Given this list of marker genes NMRAL1, ASS1, here is a description of the gene set: Reactome Pathway: ASS1 variants cause citrullinemia Argininosuccinate synthase (ASS1) plays a critical role in the detoxification of ammonia, catalyzing the third step of the urea cycle, the ATP-dependent condensation of citrulline and aspartate to yield argininosuccinate. ASS1 is a cytosolic enzyme that is expressed at highest levels in hepatocytes, but is also expressed in the kidney at lower levels. <br>Mutations in ASS1 cause type 1 citrullinemia (OMIM 215700), an autosomal recessive inborn error of metabolism affecting ~ 1 in 250,000 live births. Like other urea cycle disorders (UCDs), citrullinemia is characterized by hyperammonemia. Enzyme deficiency is also associated with high plasma levels of citrulline, glutamine, and orotic acid, with low arginine. Severe cases of citrullinemia result in encephalopathy, characterized by lethargy, vomiting, seizures, coma and death. <br>Over 100 distinct disease-causing variants have been cataloged, including missense, nonsense, splice-site, deletions, and frameshift mutations. While some variants are identified in multiple cases, such as the most common allele G390R, others are private. Missense mutations typically disrupt enzyme folding or active‑site interactions (citrulline/aspartate binding), reducing catalytic activity.<br>Nonsense, frameshift, or splicing variants can truncate the protein or eliminate key exons, resulting in non-functional or absent enzyme. part of: Diseases of the urea cycle studied in species Homo sapiens